The following is a description of a gene set: Mouse Gene Set: REACTOME_REGULATION_OF_TP53_ACTIVITY studied in species Mus musculus Regulation of TP53 Activity, and this is the list of marker genes: Sgk1, Pip4p1, Gatad2b, Taf4b, Gatad2a, Hus1, Rictor, Wrn, Rad9b, Pou4f1, Ubb, Ing5, Kmt5a, Jmy, Prkag3, Mapkap1, Pip4k2c, Mapk11, Mdm4, Brpf1, Ehmt1, Prkaa2 (NCBI Gene Id 66516), Taf9, Rpa2, Prr5, Mapk14, Kat6a, Ppp1r13b, Ak6 (adenylate kinase 6), Ppp2ca, Ppp2r1a, Rbbp7, Akt2, Smyd2, Atm, Phf20, Top3a, Nbn, Pou4f2, Zfp385a, Ccna2, Rffl, Taf7, Rad17, Mdm2, Taf13, Hipk1, Prkab1, Mre11a, Rbbp4, Rfc3, Brca1, Daxx, Ccng1, Taf15, Trp63, Bard1, L3mbtl1, Csnk2a1, Pdpk1, Taf12, Brd1, Noc2l, Cdk2, Ttc5, Pip4k2a, Trp53, Uba52rt, Kat5, Csnk2b, Banp (NCBI Gene Id 53325), Hipk2, Rmi2, Prmt5, Nuak1, Taf11, Prkag1, Map2k6, Rad1, Rps27a, Taf9b, Tpx2, Uba52, Aurkb, Brip1, Prkag2, Exo1, Usp2, Chd4, Dyrk2, Chek1, Brd7, Rfc2, Trp53bp2, Mapkapk5, Pin1, Ubc, Atrip, Cdk5, Tbp, Plk3, Ppp2cb, Usp7, Rmi1, Blm, Taf1, Taf4, Rfc5, Taf3, Akt1, Mtor, Prkaa1, Cdk1, Rpa1, Taf6, Rad9a, Trp53rkb, Mta2, Ppp1r13l, Rbbp8, Rfc4, Cdk5r1, Trp53inp1, Hdac1, Ep300, Mbd3, Csnk2a2, Supt16, Ssrp1, Pml, Topbp1, Ppp2r1b, Akt3, Prkab2, Ehmt2, Chd3, Rad50, Taf10, Taf2, Chek2, Dna2, Rpa3, Mlst8, Ccna1, Taf5, Rhno1, Rnf34, Brpf3, Pip4k2b, Ppp2r5c, Ing2, Stk11, Trp73 (NCBI Gene Id 22062), Meaf6, Aurka